Given this list of marker genes TGFB3, NUMB, KAT2B, CDK20, CCNT2, CALM2, CCNB1, VEGFA, BOD1L2, PTN, VEGFB, KLHL18, NCAPD2, ESRRB, TNKS, AURKB, NCAPG, FGF2, CCNE2, BCL2L1, ARL3, PARD6G, TTC28, NUMA1, NLRP5, UBE2I, GKN1, CEP55, PIK3C3, RHOB, FUT9, CHMP5, DCTN1, CCND1, STAMBP, STAG2, TRIOBP, GNAI2, CDC14B, CKAP2, HELLS, KIF20B, STOX1, CCND3, CNTROB, DOCK7, THBS4, CCNK, TEAD3, CEP164, PDGFA, TADA2A, ABRAXAS2, CALM3, ARL8B, MIS18A, BABAM2, SEPTIN11, CSPP1, ZNRD2, SNX9, ACTR8, DLL1, NEK9, EPB41, NDUFS6, RAB10, CDK5, BTC, OIP5, RECQL5, CCNY, BUB1, TIMELESS, TDRD12, ZNF16, CSNK1A1, SEPTIN2, CENPV, SEPTIN8 (septin 8), CDC25B, CUL7, MYC, AHCTF1, ZNF207, KMT5A, ZW10, TACC3, OR1A2, PLK3, ING2, SEH1L, MIS12, CDCA5, CCNA2, LZTS2, PLEC, KATNA1, OR2A4 (olfactory receptor family 2 subfamily A member 4), FZD7, CDC7, NUDC, CCNF, CDK1, CEP63, CUL3, PAX6, CENPS, IL1A, ERCC6L, KLHDC8B, ARL8A, CDC20 (cell division cycle 20), PDGFD, MTCL1, SEPTIN5, KIF4B, NUMBL, CDC25A, HEPACAM2, PARD3B, KLHL9, FGFR2, ANLN, CCNB2, EVI2B, LLGL2, PDXP, GNL3, CETN1, GIT1, KIF23, RASA1, WNT3A, EFHC1, RB1, ANK3, CCNE1, LUZP1, MRGPRX2, EXOC7, TUBA1B, NOX5, SMC1A, CDCA8, CCDC124, VRK1, PPP2R2D, CDK3 (cyclin dependent kinase 3), NEK3, ZFYVE19, DCT (dopachrome tautomerase), EPB41L2, MAPRE1 (NCBI Gene Id 22919), ACTR3, CTDP1, KNTC1, UNC119, PGF, CXCR5, ZWINT, VPS4B, STMN1, MTCL2, MAPRE3, RBBP8, ZWILCH (NCBI Gene Id 55055), SYCE2, ANAPC13, USP37, MARK4, HMCN1, WASHC5, MIR145, PADI6, CDK2, PPP1CB, SETDB2, PIK3CB (phosphatidylinositol-4,5-bisphosphate 3-kinase catalytic subunit beta), SGO2, CDC14A, TLE6, MAEA, SPIRE2, MICAL3, SFN, HTR2B, DSN1, FAM83D, PHF13, EXT1, SEPTIN14, CENPC, CLASP2, FBXO5, CCNA1, HAUS1, STAG1, RGS14, ARPP19, PIMREG, MPLKIP, HAUS5, BBS4, BRSK2, PDS5B, BECN1, SYCP1, SPAST, DYNC1LI1, OPN1MW, PPP1CC, MAP10, KLHL22 (NCBI Gene Id 84861), CD2AP, NAP1L2, KIF13A, SNX18, NEK6, HAUS2, SYCP3, UBE2C, MTMR4, PIN1, CALM1, BUB3, INSC, ARHGEF2, DR1, VEGFC, USP8, TSG101, CNTRL, ANAPC7, TPPP (NCBI Gene Id 11076), ZNF449, LEF1, SIRT2, PIK3R4, PDCD6IP, ECT2, REEP3, CHFR, RAE1, BIRC6, TRIM36, SGO1, PRC1, CCP110, POLDIP2, NSMCE2, OPN1MW2 (opsin 1, medium wave sensitive 2), KLHL42, ZFP36L2, NCAPH, MAD2L2, MCMBP, PDGFC, KLHL13, ANKRD53, SSNA1 (NCBI Gene Id 8636), NUP37, PKP4, NDC80, KLHL21, ROCK2, SEPTIN1, RAB11FIP4, CHMP2B, ORC4, YBX1, SMC2, KIF3B, RCC2, NOTCH1, UBE2S (NCBI Gene Id 27338), TACC1, TPR, FGF4, BRCA2, RALA, HAUS7, KIF18B, CKAP5, MBIP (NCBI Gene Id 51562), IQGAP3, WAPL, DCTN3, NR3C1 (NCBI Gene Id 389335), INCENP, ANXA11, E4F1, CCNB3, FGF3, RXFP3, ZBTB16, ASPM, MIS18BP1, CDK4, CDC42, KATNB1, NR5A2, TP63 (tumor protein p63), USP16, CHMP4B, THOC2, GPR15LG, BIN3, CAT, LMLN, GAREM1, CIB1, PRDM15, WWTR1, SKA1, DCDC1, CCDC66, EXOC1, HAUS4, EXOC2, FGF13, EML3, YTHDF2, TOP1, USP9X, MAD2L1, MYH14, DIXDC1, MTMR3, PRKCE, DIS3L2, ANAPC5, BRIP1, NSUN2, SYCE3, EXOC6B, KAT14, TXNL4A, SEPTIN9, OPN1LW, CHMP4C, PPBP, PARD6B, CLASP1, BOD1, MYH9, ROPN1B, POU5F1, CINP, CLTC, ANKLE2, NCAPG2, VANGL2, TEX14, KIF20A, INTS13, SMC5, KAT2A, ANAPC11, FGF6 (fibroblast growth factor 6), CDK14, CLTA, SEPTIN4 (NCBI Gene Id 5414), JTB (NCBI Gene Id 23561), NEDD9, CENPT, RCC1, SENP5, FGF9, TAS1R2, RAB35 (NCBI Gene Id 11021), LIG4, TUBA1C, NUF2, PAFAH1B1, YME1L1, FUT10, NUP62, WNT7A, RACGAP1, WDR5, PMF1, FGF8, CDC16, TAL1, ENSA, CDK7, OOEP, CCNT1, KIF2B, SAC3D1, TENT4B, PTCH1, CUZD1, RAN, DYNLT1, NSL1, POU3F2, ANAPC10, CETN2, WNT9B, BCAR1, RPS3, DYNC1H1, CABLES1, CHEK2, MACC1, NUSAP1, CDC23, BABAM1, SETD2, CHMP3, EML4, KIF14, NCOA3, SPART, TGFB2, RTKN, SEPTIN6, EXOC3 (exocyst complex component 3), TOP2A, PDS5A, APC, TGFA, H3-4, DYRK3, MITD1, TPX2, EXOC6, DYNLT3, ETV5, CDKN2A, FGF7, MYB, FIGN, SOX5, IQGAP1, VEGFD, TGFB1, SAPCD2, CENPA, E2F8, DRD3 (dopamine receptor D3), TOPAZ1, PSRC1, CHMP4A, CDC6, SPOUT1, CIT, NCAPD3, CDK6, TIPIN, CDT1, ENTR1, NEK4, OSM, CHMP7, GOLGA2, TPRA1, BLM, MYH10 (NCBI Gene Id 4628), AURKA, MAU2, GNAI3, CDCA2, ESPL1, BORA, SPECC1L (sperm antigen with calponin homology and coiled-coil domains 1 like), CHMP1B, EREG, FSD1, NEK2, KIF11 (NCBI Gene Id 3832), TADA3, TXNIP, HAUS6, SPC24, TTC19, BIRC5, PRPF40A, SPDL1, VPS4A, DCLRE1A, TAS2R13, SKA3, SMC4, LIG3, CCNG1, CHMP2A, PKN2, SNX33, TUBB, ITGB1BP1, SPATA22, AATF, ARF1, NRDE2, FZR1, SMC3, CETN3, CECR2, PDGFB, RHOA, IST1, REEP4, CABLES2, ACTR2, CENPJ, RACK1, KNSTRN, KIFC1, KIF2A, SPC25, FBXL7, SEPTIN12, ZC3HC1, CCND2, CKS2, CENPW, UVRAG, ALKBH4, PLK1, EXOC4 (NCBI Gene Id 60412), MAP9, PPP1R1C, INTU, ZNF830, KIF4A, PPP1CA, MAD1L1, SMYD5, MLLT3, RHOC, SYCP2, CKS1B, BRCC3, CDK2AP2, CHMP6, RAD21, IL1B, ANAPC16, MAPRE2, CDCA3, IGF2, SGF29, MAP4, RUVBL1, SHH, EVI5, IQGAP2, SPIRE1, LRRCC1, SPAG5, ZNF365, GNAI1, CDC26, KIF2C, EXOC5, SYCE1, HNRNPU, SHCBP1L (NCBI Gene Id 81626), ZZZ3, PLK5, HMGA2, TUBA1A, FGF5, SSTR5, TERF1, ERCC2, SON, SFRP2, SPICE1, GPSM2 (NCBI Gene Id 29899), SH3GLB1, SEPTIN10, AURKC, MISP, FMN2, INO80, CDC14C (NCBI Gene Id 168448), PARD3, USP39, NEK1, NDE1, ITGB3BP (integrin subunit beta 3 binding protein), SKA2, WASL, SPTBN1, NUP43, FGFR1, NKX3-1, KNL1, LATS2, POGZ, LATS1, PARD6A, CDC27, ARF6, CCNG2, PROK1, LIG1, HDGF, CENPE, RAB11FIP3, DRD2, USP44, BMI1, LBH, SVIL, WNK1, NEDD1, MDK, CENPX, WEE1, RAB11A, EXOC8, CHMP4BP1, ATXN10, FGF1, ANAPC4, SOX17, KDF1 (keratinocyte differentiation factor 1), SDE2, HOXB4, ROCK1 (NCBI Gene Id 6093), ZFYVE26, CHMP1A, POU3F3, SUSD2, CCNO (NCBI Gene Id 9998), PELO, GIPC1, E2F7 (E2F transcription factor 7), AKNA, RNF8, CFL1, CCSAP, CDC25C, ANAPC2, ANAPC1, CENPF, SEPTIN3, HAUS3, ANAPC15, MASTL, RALB, YEATS2, SEPTIN7 (NCBI Gene Id 989, septin 7), HAUS8, MYO19, BUB1B (NCBI Gene Id 701), PTTG1, here is a description of the gene set: Human Gene Set: GOBP_CELL_DIVISION studied in species Homo sapiens The process resulting in division and partitioning of components of a cell to form more cells; may or may not be accompanied by the physical separation of a cell into distinct, individually membrane-bounded daughter cells.